The following is a description of a gene set: studied in species Homo sapiens HDL remodeling Human Gene Set: REACTOME_HDL_REMODELING, and this is the list of marker genes: APOC3, LIPG, APOC2, LCAT, PLTP, CETP, APOE, ABCG1, ALB, APOA1